Given this list of marker genes TMEM199, THEMIS, SSUH2, GPR139, ELOVL7, PIK3CA, PDE12, TIGD6, MSRB3, RIMS4, TRIT1, CHST11, BSPRY (B-box and SPRY domain containing), MRPL32, TPP2, ABCA1 (ATP binding cassette subfamily A member 1), KCNIP1, SRSF8, UBTD2, METTL8, ESRRG, TAF12, LPIN2, ARB2A, HLA-B, MAGI3, PRRC2C, LDAH, YY1, PRKN (NCBI Gene Id 8004), ATF7IP, PTGS1, TNFRSF19, NCALD, CNTNAP2, TP63, MANSC1, CAMK1D, MRS2, CTDSPL, CD99L2, GOLGA6C, ZBTB20, SH3PXD2A, CLPTM1L (NCBI Gene Id 81037), ZEB1, AOPEP, NKRF, EIF5A2, PPIP5K2, UBN2, SNX19, MYRIP, TMPPE, FABP3, DUSP16, B3GNT2, SLC4A9, LRRTM3, ZNF584, ZNF780B, SRSF9, ACO1 (aconitase 1), PHF24, LZTFL1, TRIM33, COLCA1, TMEM45A, PADI1, EIF2B1, CRIPTO, ETF1, HGSNAT, GATA6, UBE3A, ATP5MG, RNF20, DDAH1, LOX, GNB4, RAB20, DNAJB4, BRWD1, NFAT5, KLHL15, MECP2, DNAJC30, CHCHD3, EYA4, HAPSTR2, IL6ST (interleukin 6 cytokine family signal transducer), HAL, ALG2, SLC30A4, CEP68, BACH2, RNF114, DLG4, CLCN3, RYK, CD84, CASP14, DERL2, NOL6, GFM1, DNMT3A, RNF180, NUMBL, LRP3, SHC3, CR1 (NCBI Gene Id 1378), MED17, NAV3, GDPD1, PARG, ABCA12, HHIP, DHCR24, KLHL12, KCNIP4, ZC3H4, TVP23C, CDK6, EGLN3, MEGF10, JADE1, SUMO2, TSNAX, KCNQ3, PRLR, NINJ1, TIGAR, MLIP, IFNGR2 (interferon gamma receptor 2), IL1RAPL2, PCID2, SH3TC2, MLLT3, PHC3, VEGFA (NCBI Gene Id 7422), DNM1L (NCBI Gene Id 692222), UBE2R2, ZNF395, CAST, THAP12, GCOM1, SEMA4D, STAT3, KIF13A, POLR2M, GPD1, MTX3, GRIA2, MBNL2, LRRC10, UNG, SETDB2, TENM1 (NCBI Gene Id 10405), KDSR, RASL11B, SH3BGRL2, ASB7, EPHA7, FN3KRP, AEBP2, CYP4F2, AGO2 (argonaute RISC catalytic component 2), HOXC10, CD24, MPZ, TWSG1, SLC2A12, SH3BGR, PTCH1, HPS3, ADAM21, PRKD3, C6orf62, MYSM1, TWF1, ZNRF1, SPOP, CPT1A, BTAF1, GAS8, MYCL, HCN4, MOB1A, SCN5A (NCBI Gene Id 652341), PAQR3, SLC2A5, CREBZF, ITCH, KRTAP1-3, CBLB, ZMYM2, TMEM196, DHRSX, LENG8, PGR, EDEM1 (ER degradation enhancing alpha-mannosidase like protein 1), RGS8, C1orf21, SLC30A9, PF4V1, ZNF850 (zinc finger protein 850), SPTSSA, BTBD1, CCER1, PTBP1 (NCBI Gene Id 63477), GET1-SH3BGR, DRD1, ARF6, GRIA3, TM9SF3, RALGAPB, SOX6, CEP170, PHTF2, ERCC2, GPR3, CD22, SUDS3, CD164, GPR158 (NCBI Gene Id 57512), GLT1D1, SLC27A2, IFT52, GBX2, MAPRE2, GZF1, EVC, TFDP2, CTCF, TOR2A, BMPR2, GNPDA2, ZSCAN2, MAN2A1, IFT56, GPR161, MCU, MXD1, SULF1, RTL8B, NEUROD1, BICD2, MID1, GPM6B, GTF3C4, AFG2A, CFLAR, TAPT1, MBNL3, TMEM167A, DISC1, TMEM72, MAP1B, RASGRP2, CEP162, SLC16A10 (NCBI Gene Id 55457), GIPC3, ZBTB38, NAA25, TTC28, TCFL5, RBM18, NSD2, CD34, IGF2BP3, CNOT2 (NCBI Gene Id 51498), FANCF, GPATCH8 (G-patch domain containing 8), FBRSL1, CEP41, KDM6A, TRABD2A, TMEM64, SKIL, VPS41, ZFHX3, PRKCB, G3BP2, RASEF, MC2R, RBFOX2 (NCBI Gene Id 23543), FNBP1, TMOD2, ATP13A3, PARVA, GLCE, TPP1, WDR48, CEP44, STAMBPL1 (NCBI Gene Id 57559), IL31RA, HLA-A, SCML1, RLIM, ARHGAP45, TESPA1, ENPP6, PROX2, ADAMTS5, KLF2, CSRNP3, KIAA1217, GXYLT1, CTBS, RTL5, NPAP1, HIPK2, TCF20, MIER3, CCDC47, CYP4F3 (NCBI Gene Id 89256), CHST10, ARFGEF2, ETS1, CDKAL1, PDXDC1, TOX3, ANKMY2 (ankyrin repeat and MYND domain containing 2), PCDH7, ZNF326, BTN2A2, ATP6V0C, GPR107, OTULINL, SHISA6, A1CF, LHX9, HECA (hdc homolog, cell cycle regulator), CLK4, MAST4, here is a description of the gene set: Genes predicted to be targets of miRBase v22 microRNA hsa-miR-1299 in miRDB v6.0 with MirTarget v4 prediction scores > 80 (high confidence targets). species: Homo sapiens Human Gene Set: MIR1299 from publication Chen Y, Wang X (PMID 31504780)